The following is a description of a gene set: species: Mus musculus TNFR1-induced proapoptotic signaling Mouse Gene Set: REACTOME_TNFR1_INDUCED_PROAPOPTOTIC_SIGNALING, and this is the list of marker genes: Rbck1, Xiap, Rnf31, Tnfrsf1a, Tnfaip3, Otud1, Usp2 (NCBI Gene Id 53811), Birc2, Cyld, Usp21, Ripk1, Usp4, Tradd, Tnf, Otud7b, Tbk1 (NCBI Gene Id 80470), Fadd, Ikbke, Birc3, Spata2, Traf2, Mib2